The following is a description of a gene set: studied in species Mus musculus from publication Suzuki T, Kosaka-Suzuki N, Pack S, Shin DM, Yoon J, Abdullaev Z, Pugacheva E, Morse HC 3rd, Loukinov D, Lobanenkov V (PMID 20231363) Genes up-regulated in testis tissue upon knockout of CTCFL. Mouse Gene Set: SUZUKI_CTCFL_TARGETS_UP Previously, it was shown that the CTCF paralogous gene, BORIS (brother of the regulator of imprinted sites) is expressed in male germ cells, but its function in spermatogenesis has not been defined. To develop an understanding of the functional activities of BORIS, we generated BORIS knockout (KO) mice. Mice homozygous for the null allele had a defect in spermatogenesis that resulted in small testes associated with increased cell death. The defect was evident as early as postnatal day 21 and was manifested by delayed production of haploid cells. By gene expression profiling, we found that transcript levels for Gal3st1 (also known as cerebroside sulfotransferase), known to play a crucial role in meiosis, were dramatically reduced in BORIS KO testes. We found that CST is expressed in testis as a novel testis-specific isoform, CST form F(TS), that has a short exon 1f. We showed that BORIS bound to and activated the promoter of CST form F(TS). Mutation of the BORIS binding site in the promoter reduced the ability of BORIS to activate the promoter. These findings define transcriptional regulation of CST expression as a critical role for BORIS in spermatogenesis., and this is the list of marker genes: Ppy, Camk2d, Zfp704, Igkv9-123, Myf6, Ckm, Adk, Dbndd2 (NCBI Gene Id 99295), Tff1, Mdn1, Septin1, Klrh1, Nop58, Ubp1